The following is a description of a gene set: Genes predicted to be targets of miRBase v22 microRNA mmu_miR_5124a in miRDB v6.0 with MirTarget v4 prediction scores > 80 (high confidence targets). from publication Chen Y, Wang X (PMID 31504780) species: Mus musculus Mouse Gene Set: MIR_5124A, and this is the list of marker genes: Ptger4, Bmp1, Phrf1, Ston2, Ccn2, R3hdm1, Cltc, Lypd3, Zdhhc14, Camsap2, Ptcd1, Tln2, Clptm1, Ddr1, Slc5a7, Psd3, Carmil1, Zfp579, Ndufaf4, Chic1, Ptges2, Slc33a1, Rgs10, Vapa, Gjd4, Srgap1, Ccnd2, Epha4, Kpna4, Hspa5 (heat shock protein 5), Fnip1, Med6, Dyrk1b, Epn1, Me1, Tagln2, Sh3pxd2a, Spats2, Cxcl16, Pi4ka, Bmerb1, Fsd1l, Col4a3, Plekhh1, Prr14l, Ebf2, Zfp825 (zinc finger protein 825), Nudt10, Vsnl1, Adgrl4, Pigt, Rpl27a, Aph1a, Faxc, Ptbp3, Kif5c (NCBI Gene Id 16574), Txlng, Arpc5, Nlk (nemo like kinase)